Given this list of marker genes CAPN10, CAPN9, CAPN3, ADGB, CAPN2, CAPN12, CAPN7, CAPNS2, CAPN6, CAPN13, CAPN5, CAPN8, CAPN11, CAPN1, CAPNS1, CAPN14, CAPN15, here is a description of the gene set: Human Gene Set: GOMF_CALCIUM_DEPENDENT_CYSTEINE_TYPE_ENDOPEPTIDASE_ACTIVITY Catalysis of the hydrolysis of nonterminal peptide bonds in a polypeptide chain by a mechanism using a cysteine residue at the enzyme active center, and requiring the presence of calcium. studied in species Homo sapiens